Given this list of marker genes SOX8, TMEM119, LRP5, GATA1, HPSE (heparanase), BMP2, FBLN5, ITGB3, ABL1, CTHRC1, CCN1, ITGAV, LTF, here is a description of the gene set: Human Gene Set: GOBP_POSITIVE_REGULATION_OF_OSTEOBLAST_PROLIFERATION species: Homo sapiens Any process that activates or increases the rate or extent of osteoblast proliferation.